Given this list of marker genes ZNF296, ZNF212, PTCH1, SNAPIN, PLXNB2, PRKCQ, ADORA2A, UQCRQ, PDZD7, PDE6C, RAPGEF2 (NCBI Gene Id 9693), APOA4, SPART, TIAM1, NRXN3, PUM2, SETX (NCBI Gene Id 85506), AP5Z1, TRIM32, ROM1, STXBP1, SPG11, ADGRV1, FBXW8, RAB17, CCK, IFRD1, FGF8, EMX1, PARD3, LGI4, EDN2, PGRMC1, CECR2, UBB, SMIM45, RAB11A, NSMF, SYT14P1, MEF2A, MINAR2, DBNDD2, DICER1, CRKL, ITSN1, STX1B (syntaxin 1B), PTPRZ1, KIF5B, RAB3A, FBXO7, ABL2, IL6, MT3, EVL, HEXA, SEMA3D, ATOH7, HES5, PJVK, PMP22, CSMD3, GBX2, DLX5, GLDN, FOLR1, TBCD, C3, DRD2, CEP290, TP73, TWF1, P3H1, RNF157, PPP1R12C, PTPN1, TSPAN2, EFNA4, PLPPR4, TMC1, L1CAM, TLX2, TUBA1A, CYFIP2, TOX, RETREG3, TDP2, ARHGAP44, NLGN3, SYNGAP1, FGFR1 (fibroblast growth factor receptor 1), ZNF335, TRIP11, PPFIA2, RORB, TH, SEMA4F, NTRK2, APLP2, SHANK1, FSHR, VIM, TAOK3, RAB29, NR2F1, NTN4, NCK2, DIP2B, NLGN1, MACF1, IQSEC1, HDAC2, WDR47, TENM4, SLITRK3, CAMK2G, TRPC6, KATNB1 (NCBI Gene Id 10300), SAMD14, NTRK1, ELAVL4 (ELAV like RNA binding protein 4), EFNA2, KIFBP, BLOC1S1, ITGA1, TBX6, DCLK2, SDK1 (NCBI Gene Id 221935), DZANK1, ADAM17, DGUOK, USP9X, ULK2 (NCBI Gene Id 9706), GABRB1, OPCML, SEMA3A, GPM6B, POTEF, GNAT1, CTTN, KREMEN1, VRK1, C1QL1, FBXO41, GFRA1, SLC9A6, SLC4A7, BLOC1S4, LLPH, B3GNT2, ARHGAP33, BHLHE23, MNX1 (motor neuron and pancreas homeobox 1), PLS1, EIF2AK4, UNC5C (NCBI Gene Id 8633), EPHA7, TWF2, AUTS2, LGI1, FOXO6, EP300, ANAPC2, RND1, BBS1, TENM2, SLC1A3, KAT2B, S100B, STX3, CDK5, ADNP (NCBI Gene Id 256440), DNM2, ARHGEF28, ITM2C, DRAXIN, NKX2-8, AP2A1, WNT5A, TTC36, SPP1, INPP5F, GRXCR2, APLP1, MAP1B, HECW1, FLRT2, LAMB2, FEV, ERCC6, CUX2 (NCBI Gene Id 23316), CPNE6, ADGRF1, SCARF1, PITPNA, AGBL4, UGT8, PARD6B, NOVA2, PAK6, DLG5, SHANK3, NEUROD4, PTPN9, KIF26A, SRCIN1, GAP43, NCAM2, IL15RA, PTPRD, NCAM1, CLSTN3, NTF4, IQGAP1, ATF1, HOXD10, IFT140 (intraflagellar transport 140), ISL2, NOG, GRIN3A, MAP2K2, PRPH2, VPS13A, CXCL12, KDM1A, NAGLU, AGER (advanced glycosylation end-product specific receptor), PLK5, FIGNL2, SMURF1, AGRN, EPHB3, NTNG1, PTK2, NEDD4L, NEUROD1, RPL24, RDH13, MBOAT1, ROBO3, CDK5R1, CNTN2, BMP7, ZFYVE27, SLITRK2, XK, PRKCA, DENND5A, GATA2, LYN, MKS1, MARK1, ADCY10, SEMA3F, STRN, VSX1, TMEM132E, ALS2, NR2F6, ANOS1, ARL3, MYOC, OTOGL, PLP1, GRXCR1, SLIT3, SCYL1, KIDINS220, SHTN1, ITPKA, CDKL5, GABRA5, PHGDH, NRDC, PTPRS, PPP1R12A, NRP1, RAB21, SVBP, DCC, FARP1, STK11, NGF, BRSK2, BTBD3, ADARB1 (adenosine deaminase RNA specific B1), NTRK3, DAB1, HERC1, PRDM1, FSTL4, PBX2, BOC, CFLAR, TRAPPC4, DIP2A, NANOS1, GFRA3, TNN, IGSF9, GAS7, GAK, AGTPBP1, SECISBP2 (SECIS binding protein 2), MYCBP2, DRD1, UNC5B, TAOK2, PLEKHG4, PACSIN1, CAMK1D, PLXNA3, MAG (NCBI Gene Id 4099), GPRIN1, ATOH1, GNAT2, EFHD1, LRRC4C, THOC2, NEO1, PPP2R5B, SDC2, CNR1, NEUROD2 (neuronal differentiation 2), OTX2, MMP2, SIPA1L1, SARM1, RTN4RL1 (reticulon 4 receptor like 1), CDKL3, POTEJ, KIF1A, EPHA8, PLXNA4, FRY, SPOCK1, JAK2, FZD1, MAP4, C12orf57, PPP1R9A, FLOT1, OGDH, RHOA, UHMK1, PLXNC1, CASP3, PRKCZ, ABI1, ARK2C, FN1, TRPV2, GPC2, LRP8, PHACTR1, EFNA5, GSK3B, RAB13, IL1RAPL1, CD2AP, GDF7, DSCAM, TENM1 (teneurin transmembrane protein 1), TSC22D4, HOXA2, BRAF (B-Raf proto-oncogene, serine/threonine kinase), FUT9, CD38, YTHDF1, NHERF1, POTEI, RB1, PPP3CA, RERE, CAMK1, ZNF365, BARHL2, NEURL1 (neuralized E3 ubiquitin protein ligase 1), AFG3L2, PRKG1, RAB37, NRCAM, ABI3, NTN3, CIB1, CUL7, BAIAP2, B2M (beta-2-microglobulin), SEMA5B, PAFAH1B1, RNF220, TRIM67, ZPR1, LHX6, MIR222, ATP9A, CABP4, NRN1L (NCBI Gene Id 123904), HOXD9, NREP, SEC24B, RYK, CRMP1, MTCH1, NMNAT2, MCF2, MDM2, SPG21, PTPRU, MAP1S, EPHB2, NTM, NFIB, MAP3K13, DDX56, CAPRIN2, NRL, RTN4RL2, NIN, TSKU, GNGT1, GFI1, GBA1, MFSD8, PTPRM (NCBI Gene Id 5797), TRIOBP, CTNNA2, RELN, ARC, ANKRD1, GRIP1, C1QA, ITSN2, NPHP4, BCL11A, SLC39A12, VCL, NEXN, NCKAP1, SLC12A5, GRID2, CRK, GIT1, TGFB2, TRPV4, CERS2, PTPN11, RASAL1, LMO4, KIF5A, UCHL1, EDNRB, LRIG2, WNT3, NBL1, GPX4, GBX1, IL2, DIO3, BDNF, ITGA6, PRMT1, LZTS3, LTK, SLC38A8 (solute carrier family 38 member 8), WEE1, ADCY6 (NCBI Gene Id 23320), PBX3, RAPH1, NEUROD6, KEL, RGMA, NPTN, RAC1, CELSR3, DPYSL5, CNTNAP2, FYN, SHOC2, CNGB1 (cyclic nucleotide gated channel subunit beta 1), EPHA10, DBNL, LIMK1, ECE1, LHX4, POU3F2, ETV1, KANK1, FEZF1 (NCBI Gene Id 392779), CAMSAP2, CRPPA, SLC30A1, SERPINF1, IFT20, ACTL6B, SOD2, CNTN1, ABLIM1, NEFH, ARX, SLITRK1, RPGR, OLFM1, UCN, WNT7A, PAK4, NFATC4, EPHA4, RAB6A, EDNRA, CC2D1A, FKBP4, POTEKP, LRP12, NUMB, THY1, PPP1R9B, KLK6, RPGRIP1, SPAST, THRB, NKX6-1, CX3CL1, SMAD1, USH1C, ROBO2, SRGAP2, PAX2 (NCBI Gene Id 5076), FES, GLI2, RAC3, BICDL1, CLN5, CHN1, LONRF2, ARHGEF25, SMAD4, RUNX3, WNT3A, ZDHHC15, KIF21A, CDKN1C, INSM1, DMD, FRMD7, NKX2-1, PPP3CB, PLXNB1, ABI2, DAG1, NRP2, FLRT3, ACP4, NCKIPSD, DHFRP1, MAGI2 (NCBI Gene Id 9863), ARTN, RNF6, SCYL3, CUX1, MDK, ARSB, UNC5D (unc-5 netrin receptor D), CLRN2, NUMBL, BBS4, WNK1, VAX2, RAP2A, POSTN, ARMCX5-GPRASP2, FLRT1, TNXB, PAX6, MYO7A, ATP8B1, FAM151B, EMB, RPS6KA5, KLF7, KIRREL3, GOLGA4, CDH1, SLC4A10 (NCBI Gene Id 57282), ZDHHC17, SNAP25, HS6ST1 (heparan sulfate 6-O-sulfotransferase 1), NECTIN1, ENC1, DGKG, SPAG6, GPR37, SFRP1, NR4A2, EPHA5, TPRN, KIF5C, NEU4 (NCBI Gene Id 129807), CAPRIN1, STMN3, PLXNA1, MAPK8IP2, MYO16, PTPRT, DISC1, PICALM, CREB1 (cAMP responsive element binding protein 1), ADGRB1, GPM6A, BRSK1, JUN, ITGA4, GBA2 (glucosylceramidase beta 2), NRXN1, EEF2K, TRIM46, SEMA3B, KLF4, EFHC2, SMO, FEZF2, LLGL1, OLIG1, SLIT2, RTN4R, SEMA3G, OBSL1, SPAG9, KCNQ1, DDR1, ALKBH1, IRX5, HPRT1, GDI1, KIAA1755, PBX1, TNFRSF21, OLIG2, CFAP418, ID2, TBCE, KCNIP2, CRABP2, MINK1 (misshapen like kinase 1), PRKD1, NOTCH2, ATXN10, SGK1, KIF20B, PITX3, NFASC, B4GALT6, MATN2, POU4F3, BHLHA15, SHOX2, WDPCP, BLOC1S2, TANC2, KNDC1, USH1G, ANKRD27 (NCBI Gene Id 84079), UNC13A, RUFY3, CACNG7, EPHB6, CAMK2A, FIG4, CPNE1, PLXND1, MYO9A, CRTAC1, CNTNAP1, GFAP, WASL, DPYSL3, UST, LHX3, DSCAML1, PTPRH (NCBI Gene Id 5794), MAPK8IP3, MECP2, BRINP1, DBN1, SCYL2, CARM1, BCL11B, NGFR, LAMB1 (NCBI Gene Id 3912), MICALL2, TNC, DTNBP1, ASCL1, BMPR1B, LAMA2, PTPRF, NEUROG3, PTK6, RUNX1, CDK5R2, ELMOD3, KIF13B, CHRNB2, DAB2, PRAG1, ATG16L1, SEMA4G, CDH11, NYAP1, BCL7A, DRGX, ZMYND8, NYAP2, C21orf91, LRRK2, ALKAL1, CD3E (CD3 epsilon subunit of T-cell receptor complex), IHH, RAP1A, MAP2, SKIL, ACTL8, VASH2, PRKCI, MTR (5-methyltetrahydrofolate-homocysteine methyltransferase), RAB10, CCDC88A, SOD1, REST, SCRIB, TNR, MUL1, STRC, ACTG1, APOE, AMIGO1, AMIGO3, WASF1, NEUROG1, FEZ1, NDN, STMN2, NR2E1, NFE2L2, TIAM2, MOV10, RGS2, PLEKHG4B, TRIO, STK25, TUBB3, FRYL, BMPR2, SEMA4D, BLOC1S3, ATAT1, WNT7B (NCBI Gene Id 7477), CLASP2, PCARE, CNTF, METRN, CSF1R, SOX1, POU4F2, SCN1B, VANGL2, PTPRO, OPHN1, CTHRC1, ITGA3, INS, TRAK2, GHRL, RP1, MAP4K4, CDC27, OLIG3, ZC4H2, MGARP, SEMA4A, NOTCH1, MTMR2, PAQR3, ISLR2, SZT2, TTL, NCS1, EGR2, SLC11A2, OR10A4, TAOK1 (NCBI Gene Id 80214), MYLIP, FBXO45, SEMA6B, STMN4, SS18L1, C9orf72, MIR200C, LMX1A, GORASP1, GABRB3 (NCBI Gene Id 2562), TMEM108, LIF, CYFIP1, SIN3A, ADGRB3, AURKA, CHRNA3, PRKN, NDP, FGF13, DVL1, SRF, OMG, CBFA2T2, ANKS1A, PCDHAC2, MAPKAPK5, TENM3, SULT4A1 (NCBI Gene Id 25830), KLK8, APBB2, CDNF, PLAA (NCBI Gene Id 9373), HDGFL3 (NCBI Gene Id 50810), VLDLR, HECW2, EHD1, CCDC39, MIR210, IGF2BP1, SCN11A, NEGR1, PTEN, LHX2, WASHC5 (NCBI Gene Id 9897), LRP2, BMPR1A, KCNQ3, RP1L1, SLIT1, ROBO1, AVIL, NRN1, SLC44A4 (NCBI Gene Id 87892), LEP, ADCY1, DOCK7, DLG4, EPHA3, COL25A1, VASP, DHFR, LHFPL5, MARK2, ISL1, SYT3, PTPRJ, UBE4B, DCDC2, MYH10, EFNA3, LST1, SYN1, ABITRAM, USP33, MIR431, TBC1D24, SYT2, ENAH, WHRN, SPRY3, SCLT1, NHLH2, FSCN2, BECN1, IST1, ZMIZ1, LYPLA2, CTNNA1, BSG, MAP7D2, SLITRK5, FZD2, APP, ONECUT2, CAMSAP3, NEDD4, PTPRG, FOXG1, GRN, PLPPR5, FAT3, STMN1, MAPK6, ZNF804A, B4GAT1, GPRIN3, MAP6, KCNB1, HCN1, PLA2G3, ACAP3, TNFRSF12A, MIR221, CPNE9, SF3A2, ALKAL2, MYOT, BAG5, ROCK1, POTEE, SEMA3E, TRAK1, B4GALT5, SLC25A46, CRB1 (NCBI Gene Id 6107), RAPGEF1, PCDH12, RND2, NR4A3, TMEM106B, OLFM3, POU4F1, PHOX2B, SDC4, CELSR2, MYT1L, SEMA6D, DDR2, PSD, CDH4, PRRX1, ERBB2, CDC20, MFSD2A, TRPC5, NTN1, PTPRK, TBR1, PSEN1 (NCBI Gene Id 5663), TUNAR, TNIK (TRAF2 and NCK interacting kinase), AKT1, EVX1, SSNA1, TECTA, VAPA, FOXB1, PARP6, KLHL1, ATP8A2, UGDH, NPTX1, KIAA0319, SRGAP2C, MINAR1 (NCBI Gene Id 23251), TOR1A, MICALL1, EZH2, XBP1, GDNF, NOTCH3, PTN, BCL2, RAB35, SPTBN4, NPR2 (natriuretic peptide receptor 2), SIAH1, MIR133B, MYPN (myopalladin), SH3GL2 (SH3 domain containing GRB2 like 2, endophilin A1), RTN4IP1, SYT1, SEMA6C, SLC23A2, LHX9, HDAC6, CFL1, HES1, RAB8A, MFRP, LPAR1, APBB1, VPS13B, EPHB1, PQBP1, GPRASP3, ARFGEF1, FEZ2, LPAR3, HMGB1, CNP, SLITRK4, CNTN5, EPHA6, CHODL, GRM7, ADCYAP1, ANK3, AREG (NCBI Gene Id 727738), ARHGAP4, IFT27, SCARB2, CAMK2B, SYT17, SRRM4, RAB6B, S100A9, CDK16, SAMD7, CNTN6 (NCBI Gene Id 27255), HAND2, FMR1, UNC5A, BTG2, PRDM12, NGEF, NCKAP1L, TOP2B, SYT4, UNK, RIMS2, RIMS1, NCDN, LGR6, SEMA7A, CDC42, SFRP2, RET, TULP1, PRDM8 (PR/SET domain 8), EFNA1, NCK1, ATL1, SEMA4B, ZEB2, YWHAZ, EFNB2 (NCBI Gene Id 1948), DVL3, POC5, ULK4, KALRN, RTN4, ITGB1, SHH, NEFL, PLA2G10, MICOS10-NBL1, FARP2, MAP1A, OSTN, PICK1, SKOR2, EN1, CTNNB1, GATA3, CNTN4, CDH23, DCLK1, NDNF, APOD, LHX1 (NCBI Gene Id 3975), ARHGAP35, EPO, TUBB2B, EFNB3, ARF6, YWHAH, GLI3, EDN3, TBC1D23, LZTS1, EXT1, SERPINI1, LHX8, ATF5, LRRC7, INPP5J, MAP2K1, HTRA2, ROBO4, ATP7A, FGFR2, DVL2, ST8SIA2, TTC8, GAREM2, CAMSAP1, DKK1, CHRNA7, PAK2, NEUROG2 (neurogenin 2), PAK1, DHX36, S100A6, LRP4, PALLD, PALS1, RIT2, SNX3, CPNE5, ACTB, ULK1, BORCS7, UPF3B, MEF2C, CPEB3, TMEM30A, ALK, TPBG, PPP1R12B, DAB2IP, PBX4, FBXO38, PPT1, UGCG, CRB2 (NCBI Gene Id 286204), PREX2, GSK3A, IMPACT, CHL1, NTF3, NR2E3, KHDC3L (KH domain containing 3 like, subcortical maternal complex member), ACTBL2, PLXNB3, NDEL1, NLGN2, EN2, TSPO, NELL2 (NCBI Gene Id 4753), SEMA5A, SEMA6A, GPRIN2 (G protein regulated inducer of neurite outgrowth 2), COBL, FZD4, MEGF8, MAPT, BLOC1S6, EPB41L3, BMP5, VPS54, ANKRD24, SEMA3C, SEMA4C, NPY, VAX1 (NCBI Gene Id 196056), SEZ6, GALR2, PAK3, BHLHE22, EDN1, SAMD11, BLOC1S5, MIR219A1, RTCA, RPGRIP1L, ARF4, STYXL1, ARHGEF40, CLRN1, MANF (mesencephalic astrocyte derived neurotrophic factor), CTNND2, ABL1, KIFC2, TCTN1, STK24, ATP1B2, AHI1, PTK2B, NRTN, NTNG2, CCKAR, ATCAY, FOXD1, CDHR1, LAMA1, PDLIM5, SLITRK6, STAU2 (NCBI Gene Id 27067), RASGRF1 (Ras protein specific guanine nucleotide releasing factor 1), PREX1, GABRB2, PTK7, DOCK10, FZD3, CLMN, ALCAM, PRICKLE1, IFT88, CTF1, VEGFA, NDRG4, SOS1, EFNB1, HMCN2, here is a description of the gene set: The process whose specific outcome is the progression of a neuron over time, from initial commitment of the cell to a specific fate, to the fully functional differentiated cell. species: Homo sapiens Human Gene Set: GOBP_NEURON_DEVELOPMENT